The following is a description of a gene set: Human Gene Set: HP_ABNORMALITY_OF_THE_GALLBLADDER An abnormality of the gallbladder. Abnormality of the gallbladder species: Homo sapiens, and this is the list of marker genes: SEC24C, NELFA, UFD1, DNAJC30, INTU, TCF4, SC5D, AIRE, GCGR, SPTB, B3GLCT, JAK2 (Janus kinase 2), CALR (calreticulin), UROS, SLC4A1, RREB1, TMEM270, CPLX1, STK11, PKHD1, CLIP2, MST1, MRPL39, GYPC, GPI, GPR101, NCF1, STX1A, ANK1, DMPK, PIEZO1, GATA6, FUCA1, SCARB2, SCNN1A, HOXD13 (homeobox D13), ABCG8, RFX6, EPB42, SEC23B, HK1, METTL27, DHCR7, GTF2I, EIF4H, CC2D2A, KDM5C, RFC2 (NCBI Gene Id 5982), POT1, FKBP6 (FKBP prolyl isomerase family member 6 (inactive)), TFE3, CYP27A1, FECH, AIP, HBB, NR1H4, CYP7A1 (cytochrome P450 family 7 subfamily A member 1), LETM1, EPB41, F5, UQCRFS1, CTBP1, BUD23, GNE, TPI1, JMJD1C, SPTA1, BLVRA, ARVCF, PNPLA2, TBL2, ALDOA (aldolase, fructose-bisphosphate A), ABCB4, ATP8B1, PSAP, PKLR, GBA1, FOXF1 (NCBI Gene Id 2294), ABCB11, ITPR1, ASXL1, SCNN1G, MECP2, PEX19, PFKM, PIGG, BAZ1B, IGKC, VPS4A, SEMA4D, HIRA, ELN, VPS37D, LIMK1, CCDC47, HGD, SCNN1B, MPV17, KCNN4, ALAS2, GTF2IRD2, SON, AMACR, GTF2IRD1, GPR35, GP1BB, COMT, NSD2, MED25, TBX1, IGHG2, CNOT1, ARSA, SMPD1